Given this list of marker genes IFT140, BRCA2, STK11, KRT18, LBR, MED12, POLG, HFE, CIITA, PEX14, ARL6, RNF43, SCARB2, ZIC3 (Zic family member 3), TCF4, TNFSF15, IL12RB1, MKS1, LETM1, STX5, RFX6, ESCO2, HSD3B7, B3GLCT, LMNA, LMBRD1, RPGRIP1L, DZIP1L, TGFB1, BCAP31, BCS1L, IL36RN, IL21R, IGHG2, ZFYVE19, SUPT16H, ITCH, ERCC4, PHKG2, SEMA4D, ARSA, CC2D2A, MICOS13, POU2AF1, BRCA1, CEP290, FARSB, RFXAP, PEX2, HNF1B, ROS1, FCGR2A, RFXANK, TMEM67, GCGR, SPIB, GBA1, NRAS, CLDN1, SLC37A4, CPLX1, PI4KA, IRF5, DCDC2, MST1, NPHP3 (NCBI Gene Id 27031), IL12A, NSD2, AKR1D1, MAP2K1, PSAP, GPR35, TMEM216, CFTR, ABCB4, VPS33B, PEX1, DOCK8, WDR35, FGFRL1, JAG1, ABCD1, FOCAD, KIF12, UGT1A1, MMEL1, IFT56, BMP6, GATA6, INPP5E, PTPN3, RFX5, PEX5, BRAF, USP9X, CYP7B1, TCTN3, TNPO3, CD40LG, CCDC28B, WDR19, ABCC2, HSD17B4, LONP1, CTBP1, TTC7A, BBS1 (NCBI Gene Id 79702), PKHD1, REL, IGKC, KIF3B, XIAP, here is a description of the gene set: studied in species Homo sapiens Biliary tract abnormality Human Gene Set: HP_BILIARY_TRACT_ABNORMALITY An abnormality of the biliary tree.